Given this list of marker genes NRG1, NRG3, ERBB4, NRG4, NRG2, here is a description of the gene set: Human Gene Set: KEGG_MEDICUS_VARIANT_MUTATION_INACTIVATED_ERBB4_TO_NRG_ERBB4_PI3K_SIGNALING_PATHWAY species: Homo sapiens Pathway Definition from KEGG: NRG // ERBB4* Mutation-inactivated ERBB4 to NRG-ERBB4-PI3K signaling pathway. Pathway ID: N01164. Pathway type: Variant. Pathway class: nt06464 Amyotrophic lateral sclerosis.